The following is a description of a gene set: studied in species Homo sapiens Genes having at least one occurrence of the motif GYCACGTGNC in the regions spanning 4 kb centered on their transcription starting sites. This matches the transcription factor binding site V$USF_Q6 (v7.4 TRANSFAC). Human Gene Set: USF_Q6, and this is the list of marker genes: NCKIPSD, AMPD2, SCYL1, ARSA (NCBI Gene Id 410), ARMCX3, PURA, TCERG1, IGSF22, ARL3, TMEM131L, NR5A1, SUPT16H, CUL5, KANSL1L, SFXN2, PGAP4, RAB3IL1, NEUROD1, FLRT1, HNRNPD, ELAVL3, EME1 (NCBI Gene Id 146956), DNMT3A, RHBDD3, NDP, TMEM132E, GTF2H1, PICALM, FOXD3, SNX16, ARMT1, HMGN1, GATA5, STT3B, PRKCE, C1orf43, RBM15B, CLN3, PFDN2, EVA1C, TEX12, PDP2, TOM1L2, AMDHD2 (NCBI Gene Id 51005), ARF6, RPUSD4, CNPPD1 (NCBI Gene Id 27013), G6PC3, VWA2, SPIB, PPCS, PCED1A, KDM6A, LRRN4CL, SELPLG, RMND1, NSD3, STMN4, PER1, YPEL5, PKN1, MPV17, ATIC, OSGEP, VPS33A, GAPDH, UBE2B, HMGN2 (high mobility group nucleosomal binding domain 2), PDIA2, SUMF1, ACAP3 (ArfGAP with coiled-coil, ankyrin repeat and PH domains 3), PRPS1, SEC11C, POLR3E, CPT1A, INTU, ALDH6A1 (NCBI Gene Id 4329), BEX1, VPS26A, ZZZ3, KDM4C, PHF20, METAP1D (methionyl aminopeptidase type 1D, mitochondrial), HAPSTR1, KICS2, DUSP7, HOXD4, EIF4G1, SIRT1, HOXA3, DUSP1, SLC4A10, SHANK1, TMED10, VPS37B, PRDX4 (NCBI Gene Id 82852), STMN1, GADD45G, NDUFS1, KAT5, DLX2, MAPKAPK3, SEPTIN3, PIAS4, BRDT, TAOK2, CD164, BRD2, RORC, BMP6, EGLN2, PRKACA, RNF146, BLOC1S1, C9orf85, SLC49A4, HOXB7 (NCBI Gene Id 3217), SLC12A6, HNRNPH2, IPO7, IGF2BP1, POLR3C, RAI14, HOXC13, NPTX1, RBBP6, ADAM10, NFX1, TCOF1, CHAC1, EGR2, SOCS2, SGO1, NOP56, EEF1B2, ASPSCR1, GYG1, TOM1, KAT14, PRR7, GLYR1, SLC16A1, FGF14, C11orf52 (NCBI Gene Id 91894), DCTN4, TRMT2A, HOXA9, AKAP10, SOCS5, SLC38A2, ATXN3, TSC22D3, EPC1, DCTN3, SLC25A33, XRCC6, PSME3IP1 (NCBI Gene Id 80011), RAMP2, CANX, GIGYF2, CTBP2, GABARAP, TRAPPC8, SYNRG, DIAPH1, MICU1, ARHGAP45, GNA13, TMEM59L, AGRP, BEX3, SNX8, IRS4, TCEAL1, GPX1, PANK3, CLEC18C, SPNS1, HNRNPM, NIT1, DYM, MCOLN1, ADAMTS3, COPS7A, ASPHD1, GNAS, COMMD3, HSPE1, AP1S2, SUGP2, GLA, PITX3, UBE4B, HEXA (NCBI Gene Id 3073), JOSD1, HRH3, IER5L, MARCHF8, NRAS, SLC23A2, GTF2A1, HOXC5, CEP57, EWSR1, CREBRF, DRC3, SLC20A1 (solute carrier family 20 member 1), DUSP9, HOXB2, CDK17, ACY1, DIP2B, ANXA6, OGDHL, TAC1 (NCBI Gene Id 6864), NRIP3, TET2, AKAP1, ZMYND12, GGN, SASH3, MFHAS1, HOXA1, CCNYL1, LONRF3, MAX, SLC38A5, PHYHIP, HPS5, DDX3X, PLEKHA6, SLC35A5, ZFX, PPP1R9B, LYPD1, STX6, AMMECR1L, ARMC6, RANBP1, CHD4, ZMYND8 (zinc finger MYND-type containing 8), IGF2R, NCALD, USP31, RARG, RNF115, MFSD5, WFIKKN2, PRELID1, FAM180A, FAM76B, BAX, LARP4, TOGARAM1, NPM1, ZNF503, PIK3R3, RAD9A, ATP6V1C1, SNX2, WEE1, FKBP11, TRIB1, KCNH4